The following is a description of a gene set: from publication Schmidt K, Hughes C, Chudek JA, Goodyear SR, Aspden RM, Talbot R, Gundersen TE, Blomhoff R, Henderson C, Wolf CR, Tickle C (PMID 19273610) Cytochrome P450 oxidoreductase (POR) is the obligate electron donor for all microsomal cytochrome P450 enzymes, which catalyze the metabolism of a wide spectrum of xenobiotic and endobiotic compounds. Point mutations in POR have been found recently in patients with Antley-Bixler-like syndrome, which includes limb skeletal defects. In order to study P450 function during limb and skeletal development, we deleted POR specifically in mouse limb bud mesenchyme. Forelimbs and hind limbs in conditional knockout (CKO) mice were short with thin skeletal elements and fused joints. POR deletion occurred earlier in forelimbs than in hind limbs, leading additionally to soft tissue syndactyly and loss of wrist elements and phalanges due to changes in growth, cell death, and skeletal segmentation. Transcriptional analysis of E12.5 mouse forelimb buds demonstrated the expression of P450s involved in retinoic acid, cholesterol, and arachidonic acid metabolism. Biochemical analysis of CKO limbs confirmed retinoic acid excess. In CKO limbs, expression of genes throughout the whole cholesterol biosynthetic pathway was upregulated, and cholesterol deficiency can explain most aspects of the phenotype. Thus, cellular POR-dependent cholesterol synthesis is essential during limb and skeletal development. Modulation of P450 activity could contribute to susceptibility of the embryo and developing organs to teratogenesis. studied in species Mus musculus Mouse Gene Set: SCHMIDT_POR_TARGETS_IN_LIMB_BUD_UP Genes up-regulated in E12.5 forelimb buds with POR knockout., and this is the list of marker genes: Fdps, Elovl6, Tm7sf2, Foxc1, Lss, Srebf2, Fdft1, Zmat4, Hmgcs1, Cyp51, Acat2, Acly, Mvd, Fgl1, Stard4, Cyp26a1, Ldlr, Insig1, Mvk, Scd1, Sc5d, Msmo1, Dhcr7, Nsdhl (NAD(P) dependent steroid dehydrogenase-like), Idi1, Sqle, Aasdh